The following is a description of a gene set: species: Homo sapiens Genes having at least one occurence of the motif GGTGAAG in their 3' untranslated region. The motif represents putative target (that is, seed match) of human mature miRNA hsa-miR-412 (v7.1 miRBase). Human Gene Set: GGTGAAG_MIR412, and this is the list of marker genes: RNF207, FAM222A, ARMC8 (NCBI Gene Id 29067), BTRC, SOX6, PRX, HNRNPD, WDTC1 (WD and tetratricopeptide repeats 1), HPS1, PHOSPHO1 (NCBI Gene Id 162466), ARRDC3, FOXO3, NKAIN2, BSN, IQSEC2, TMSB4XP8, PCF11, PPP1CB, EIF4E, FMNL2, TAOK3, CCDC88B, CLCN5, NKIRAS2, TRMT5, DDX6, CDX2, ANK2, RAB28, TMSB4X, FAM120A, MIDEAS, FAM124B, SATB1, HIF1A, CLPTM1, ZFX, WARS2, MBTPS1, CHMP7, IRF7, DAG1, CLK2 (CDC like kinase 2), MROH7, SRPRA, UBE2D2, SGMS1, CSDE1, CUL3 (NCBI Gene Id 8452), PKP4, DDX11, BRCA1, RALGPS1, ABHD3, TMEM129, TRMT11, SLC16A3, DLC1, BCL6, FKBP1A, TMEM70, CDK5R1